The following is a description of a gene set: species: Mus musculus The addition of a sulfate group to a molecule. Mouse Gene Set: GOBP_SULFATION, and this is the list of marker genes: Slc35b3, Sult2a4, Sult2a8, Sult2a3, Sult3a1, Sult2a2, Hs3st3b1, Sult3a2, Sult1b1, Sult2a7, Chsy1, Sult2b1, Sult6b2, Sult1a1, Sult1c2, Sult1d1, Gal3st2, Sult5a1, Tpst2, Sult4a1, Sult2a6, Ndst1, Sult1c1 (sulfotransferase family, cytosolic, 1C, member 1), Hs3st5, Sult2a5, Chst4, Sult6b1, Tpst1, Ext1, Ext2, Slc35b2, Sult1e1, Sult2a1